Given this list of marker genes OSGEPL1, HMBOX1 (NCBI Gene Id 79618), APOOL, ABI2, STK32C, PPARGC1B, EXOSC5 (exosome component 5), RRP1B, CD33, TRIT1, CHEK2, AAK1, CRYL1, KBTBD6, NAB2, ARL3, TDRKH, GAB3, ARV1, RUNX1, ARHGDIB, ZNF573, BAIAP2, FRAT2 (FRAT regulator of WNT signaling pathway 2), IER5L, DUSP7, LRPPRC, HACD2, ARPIN, MGST2, PEX5 (NCBI Gene Id 5830), LINC02035, ALDH6A1, ARRB1, ZCCHC14, TIMM21, RUVBL2, TPST2, ZNF112, MTMR10, ZNF106, ATP9B, PWWP2B, GLIPR1, EVL, NMNAT3, SGSM2, ATPSCKMT, TACC3, PYCARD, RXRA, BAG5, TM6SF1 (transmembrane 6 superfamily member 1), HDAC4, CAMK2G, FITM2, AGO1, RRS1, ATL3, MRPL48, APBB1IP, TBC1D5, MSTO1 (misato mitochondrial distribution and morphology regulator 1), QPRT, AGO2, ATP8B4, UBE4B, TMEM45B, TSEN2, ZNF362, PREPL, MOB3B, TSC1 (NCBI Gene Id 7248), ZNF217, AGBL5, NCF2, SUPV3L1, PINK1, CYFIP1 (cytoplasmic FMR1 interacting protein 1), ATP8A1, RIN3, DHRS9, PDLIM2, GPATCH11, SHB, COP1, HOOK3, PFAS, TMF1, YIF1B, GPD1L (glycerol-3-phosphate dehydrogenase 1 like), VPS45, GMFG, MCEE, ZNF623, DGKD, TIMMDC1, MYCL, HADH, GSTT1, LIX1L, FBRSL1 (fibrosin like 1), ORAI3, ZBTB44, MAN2A2, BRI3BP, RACGAP1, ACADSB, NFATC3, GXYLT1, TOX, SNX30, DOK3, SFXN3, ERMP1, PANK3, IRAG2, FAM168B, MAP3K3, TCFL5, ZCCHC24, MFF, GSN, ZMAT3, UGGT1, LRRC8A, NUDT6, CYB5R1, SORD, EPAS1, FAM78A, NUDT16L1, TTC3 (tetratricopeptide repeat domain 3), SPCS3, FOXJ2, TTC13, SLC19A1, TTLL12, KLHL8, VGLL4, CTTNBP2 (cortactin binding protein 2), ZYG11B, AMPD2, PPOX, BIVM, AHCY, SACS, USP22, ABAT, CLEC10A, KCTD10, IL16, TARBP1, TRAF3, ANAPC7, ARHGAP9, RFC5, MRPS5, NCKIPSD, SKAP2, RAB31, HVCN1, LIMS1, KIAA0930, MRPL3, TMEM9, ZWINT, ZBTB8A, TRERF1, METTL21A, HADHA, NACC2, DOK1, ELMO1, NDUFA5, SYNJ2BP, CNRIP1 (cannabinoid receptor interacting protein 1), HNRNPA0, SRSF6, ASAP1, WWC3, RGS18, MGME1, PTPN4, UBASH3B, CCDC6, EMB, BAIAP2-DT, POLD1, SOCS7, VCL, UTP11, MGST3, FBP1, ARB2A, PECAM1, FOXN3, here is a description of the gene set: Genes up-regulated in comparison of polysome bound (translated) mRNA before and 16 h after LPS (TLR4 agonist) stimulation. Dendritic cells (DCs) are the sentinels of the mammalian immune system and they undergo a complex maturation process mediated by activation upon pathogen detection. Recent studies described the analysis of activated DCs by transcriptional profiling, but translation regulation was never taken in account. Therefore, the nature of the mRNAs being translated at various stages of DC activation was determined with the help of translational profiling, which is the sucrose gradient fractionation of polysomal-bound mRNAs combined to microarrays analysis. Total and polysomal-bound mRNA populations were compared in immature (0h) and LPS-stimulated (4h and 16h) human monocyte-derived DCs with the help of Affymetrix microarrays. Biostatistical analysis indicated that 296 mRNA molecules are translationally regulated during DC-activation. The most abundant biological process among the regulated mRNAs was protein biosynthesis, indicating the existence of a negative feedback loop regulating translation. Interestingly, a cluster of 17 ribosomal proteins were part of the regulated mRNAs, indicating that translation may be fine-tuned by particular components of the translational machinery. Our observations highlight the importance of translation regulation during the immune response, and may favour the identification of novel gene clusters or protein networks relevant for immunity. Our study also provides information on the possible absence of correlation between gene expression and real protein production in DCs. studied in species Homo sapiens from publication Ceppi M, Clavarino G, Gatti E, Schmidt EK, de Gassart A, Blankenship D, Ogola G, Banchereau J, Chaussabel D, Pierre P (PMID 19943945) Human Gene Set: GSE14000_UNSTIM_VS_16H_LPS_DC_TRANSLATED_RNA_UP